The following is a description of a gene set: species: Mus musculus from publication Yevshin I, Sharipov R, Kolmykov S, Kondrakhin Y, Kolpakov F (PMID 30445619) Mouse Gene Set: ZFP595_TARGET_GENES, and this is the list of marker genes: Gm26560, Dnajc13, Shc1, Plcxd2, Cers6, Rab3gap1, Gm42161, Adat1, Emc8, Gm11379, Gm12313, Gm24296, Eif2d, Cngb3, Gnas, Dnmt3a, Mir7035, Tbx3os1, Aste1, Pdia3, Thap6, Tex14, Mrm2, Crem, Thoc2, Pole, Maged1, Bcl11b (B cell leukemia/lymphoma 11B), Pwwp3a, Sp1, Nkapl, Sulf1, Usp14, Gm8398, Cirbp, Tgoln1, Best4-ps, Jph4, Mphosph9, Surf6, Oaz3, Manba, Gm12057, Ipo9 (NCBI Gene Id 98447), Fhip2b, Itpr2, Parp14, Gm22150, Gm11771, Ppard, Slu7, Xpnpep3, Rabl6, Emc10, Rhot1, Pwp2, Gm12936, Mir376b, Uhrf1, Gse1, 1700029H14Rik, Gas8, Ctsh, Luc7l3, Ccr4, Cxxc1, Gm20443, 4930533L02Rik, Mir6997, Gm16096, Bmal1, H2-M5, 1700019D03Rik, Hnrnph2, Gltpd2, Ccndbp1, Trim42, Lims1, Fnta, Creb3l3, Gm15222, Slc22a19, Rtl5, Hoxa11, Bcas2, H2-K1, Ltbp1, Gmip, Gal3st1, C5ar1, Celf1 (CUGBP, Elav-like family member 1), Naa16, Tldc2, Prim2, Nrdc, Pdgfd, Gm4847, Tmem265, Sun1, Gpr35, Mzf1, Haus5, Arhgdib, Fat2, Gm19705 (NCBI Gene Id 100503460), Gla, Ddr1, Srsf1, Alg11, Uts2r (NCBI Gene Id 217369), Anapc15, Gm12620, Gnpat (NCBI Gene Id 51942), Nrxn1, Tnfrsf26, Plin2, Mir8090 (NCBI Gene Id 102465883), Pik3cb, Agpat2, Dll1, Ywhag, Usp3, Gys2, Gm19815, Paxip1, Gm22972, Triap1, Tcp11, Cplx4, Babam1 (BRISC and BRCA1 A complex member 1), 6430548M08Rik, Gm15047, Gm22270, Ddx19a, Ppp2r5c, Hmgb1, Vps8, Unc13b, Eva1b, Pspn, Slc25a41, Rffl, Pick1, Cnbd2, Tmem242, Tmed2, Itih3, Rnf4, Nav3, Setx, Sirt7, Gm14095, Ptpn11, Irf5, Tyw1, Gm5473, Kmt5c, Degs2, Nrl, St13, Tfdp1, Pds5a, Copz2, Tspan17, Kdm4d, Foxp1, Fkbp4, Il27ra, Kntc1, Git2, Cfap69, Fcna, C630004M23Rik, Uso1, Hkdc1, Tmem267, B3gat1, Pi4ka, Anp32e, Tbc1d14, A430072P03Rik, Taldo1, Park7, Fau-ps2, Lrrc75aos1, Setdb2, Yju2 (YJU2 splicing factor), Itgb1, Ext2, Gm14164, Slc23a2, Celf5, Fmo9, Gm24592, Chn1, Tulp3, Cdc42ep1, Ddb2, Dhx30, Gm43772, Npdc1, Wdr95, Ccdc14, Magohb, Trp53i13, Lrrc42, Oplah, Mir7675, Adam32, Uqcc4, Simc1, Satb1, Lingo4, Slc36a3os, Cd101, Ntpcr, Pcmt1, Synrg, Crppa, Chrna10, Mpi, Nostrin, Taco1, Capza1, Shf, Metap2, Cerk, Tmem131l, Tbc1d9b, Thrap3, 1700008O03Rik, Tubgcp3, Ltbp3, Syt3, Mcm3ap, Sinhcaf, Grip1, Ift140, Gm13662, Fam171b (NCBI Gene Id 241520), Mir770 (NCBI Gene Id 791079), Trpm1, Gm5248, Nvl, Ywhaq, Gm12492, Tomm34, Klf1, Nhsl2 (NHS like 2), Ehbp1, Fbxo42, Tceanc2, Mast1, Atp2c1, Msmo1, Gm9359, Gm11548, Mir152, Dlk1, Thpo, Hoxa11os, Hsd3b7, Pierce2, Bcl2l1, Gm30292, Gpr107, Slc43a1, H2aj, Gm12828, Eri3, Ecpas, Evl, Acsbg3, C030013C21Rik, Gm12924, Rian, 4930515G01Rik, Cd300e, Nudt5, Mpzl2, Mtmr3 (NCBI Gene Id 74302), Mepce, 5031434O11Rik, Gzmm, Map4, Mir1928, Gm11191, Mvd, Gm2174, Fndc11, Uba2, Slc38a8, Lbhd1, Vpreb1a, Lce3c, Mbtps2, Copg2, Acot11, Rora, Gm12464, Lratd1, Gm15032, Magea2, Fry, Kifbp, Cpa2, Gm14227, Med21, Spink10, Niban3, Fcgr3, Poc1a, Esr2, Pdzd2, Limk2, Gpr68, Myo15a, Adh1, Gm10443, Cacnb1, Pdzd9, Lcn12, Lrrc23, Gm11475, Gm26070, Ift81, Gm28836, Plekha6 (NCBI Gene Id 98600), Gm14111 (predicted gene 14111), Smtn, Rbm47, Il17rc, Ushbp1, Nedd4 (neural precursor cell expressed, developmentally down-regulated 4), Anxa3, Lactb2, Mrpl30, Fbrsl1, Mfn1, Ifitm10, Togaram2, Slc38a6, Cars2, Gckr, 1700022A21Rik, Fanca (NCBI Gene Id 52324), Ints13 (integrator complex subunit 13), Gtf2i, Alyref, Capn11, Ccdc9, Dnajc11, Ptp4a2, Gm12440, Ift172, Gm8421 (predicted gene 8421), Fnbp4, Phf20, Inpp5b, Tmem42, Myo5b, Islr, Rnaseh2a, Gm7094, Txndc9, Spcs1, Atf7ip, Ralbp1, Fmc1, Ndfip2, Tnik, Adar, Chrna9, Gm10531, Gm22881, Vcp, Tcp1, Ifrd1, 1500012K07Rik, Hsp90ab1, Stpg3 (sperm tail PG rich repeat containing 3), Or4c35, Defb40, Uba52, Dhtkd1, Exosc8, Sgip1, Calcoco2, Adgrl3, Golga7, Ddx23, Ninj2, Zmynd12, Cep95, Oasl2, Patj, Vmn1r86, Gm13213, Vamp1, Zfp612, Agap3, Shmt1, Pla2g10 (phospholipase A2, group X), Hspa4, Dsc1, Gm7097, Tfrc, Ctsa, Acyp1, Zfp637, Hyls1, Gm15886, Mtfr1, Gm7891, Mkln1, Plcb2, Map4k4, Tulp1, Rbms3, Idh2, Gm23382, Scrn2, Eif5al3-ps, Otud4, Raver2, Nlrc3, Gm11198, Phox2b, Fam193b, Gm12740, Gm8849, Chchd10, Tcf4, Thra, Pdlim1, Psmd2, Asgr2, Ankrd40, Tigd4, Ckap2, Faiml, Ppp1cb, Gm10069, Gm23723, Atp7a, Lalba, Gm4577, Gm8213, 6030468B19Rik, Maea, Ubxn1, Arfgef1, Rps12-ps26, Rwdd4a, P2rx7, 1110028F18Rik, Gm5764, Gm22935, Map2k6, Iho1, Fam83c, Snta1 (syntrophin, acidic 1), Cwc15, Tm4sf5 (transmembrane 4 superfamily member 5), Tmem200a, Zc3hc1, Eif4e2, Gm10532, Oser1, Bola2, Arhgap39, Mxd3, Pou2f2, Gm9887, Cyp4a28-ps, Scn9a, Tmem131, 1700003F12Rik, Dhx9, Plekhs1, Dnajc17, Rab43, Atp8b4, Npr3, Tdrd9, Tpm3, Hsp90aa1, Slain1, Hoxa7, Top3a, Fam76a, Eif2ak4, Xab2, Gm23483, Misp3, 1700052H01Rik, Cars1, Atpaf1, Txnrd2 (NCBI Gene Id 26462), Slc39a2, Mir376c (NCBI Gene Id 723856), Pou2f1, Grin3b, Znfx1, Srpk1, Armh3, Mroh1, Cdkn1a, Gm24461, Cxcr5, Chd2, Gm12650 (NCBI Gene Id 102634336), Ralgps2, Sv2b, Pcdh19, Rpl38, Gm9599, Mrpl14, Cdh13, Ino80d, Was, Bex6, Terf2, 4933408N05Rik, Aars1, Zfp276 (zinc finger protein (C2H2 type) 276), Tango2 (NCBI Gene Id 27883), Mgat5, Supt6, Vwf, Gm12125, Irf3, Nol11, Cfap251, Vps72, Gna11, Vdr, Atcay, Tns3, Defb47, Gm24469, Gm20544, Zfp532, Bcl7b, Kank3, Gm13522, Pramel7, Gm12189, Gm15610, Nudt1, Rogdi, Cenpi, Art1, Slc25a19, Xpnpep1, Mir6367, Pkdcc, Ptp4a1, 2210417A02Rik, Agfg2 (NCBI Gene Id 320059), 1810053B23Rik, Bscl2, Hnrnpu, Osbpl7, Slc1a3, Mmachc, Hars2, Nr6a1, Abcc3, Doc2g, Abcb9, Wdr75 (NCBI Gene Id 96871), Csf1r, Fbxl22, Cib1, Zfp747l1, Rcbtb1, Snrnp25, Lat2, Slc7a2, Gm5532, Amigo1, Atrip, Kptn, Znrf1, Rnf170, Gm6462, Sall1, Hspa8, Cln3, Fxr2, Gm13594, Gfi1, Gm25973, Mir376a, Slc2a9, 4933406P04Rik, Catsper2, Smg7, Maf, Glra2, Baz1b, Hapstr1, Gm5258, Spmip6, Phb1, Crb3, Nsa2, Gm11292, Ppp1r10, Arl2bp, Mat2b, Gm25917, Sf3a3, Ctbp2, Zmat1, 5830487J09Rik, Bdh2, Atp6v0d1, Rnf115, Lyl1, Gm7299, Ift122, Cygb, Ccdc47, Sass6, Shroom1, Prss54, Zic1, Mdk, Tmco2, Frrs1, Scn3a, Aatf (apoptosis antagonizing transcription factor), Rdm1, Gm11149, Rnf125, Atrnl1, Ly6g6f, Tenm4, Diaph1, Mir1199, Gm26795, Slco1c1, Utp25, 1600010M07Rik, Mir654, 9430015G10Rik, Tekt5, Tatdn2, Tmeff2 (NCBI Gene Id 77664), Gpr62, Recql5, Btbd19, 4930447F24Rik, Jakmip1, Setd1a, Gpr84, Mlxip, Serpine2, Atp8b3, Gm12654, Bcas1, Selenof, Azi2, Tpst2, Dbn1, Snph, Snf8, Zfr, Gm10062